Given this list of marker genes CDKN2B, CDKN2C, CDKN1A, CDKN1B, MEN1, MAFA, here is a description of the gene set: Insulinoma Human Gene Set: HP_INSULINOMA A type of tumor of the pancreatic beta cells that secretes excess insulin and can result in hypoglycemia. studied in species Homo sapiens